Given this list of marker genes EZH1, EARS2, KAT6B, TCP11L2, IL16, ABHD14B, EBAG9, MPHOSPH6, ZFP1, CHCHD2, RNF138, RPL13, KCNJ8, SLC25A36, POLR3E, NDFIP1, CCR7 (NCBI Gene Id 1236), PER1, XCL1, BAG5, SMNDC1, RUNDC3B, SIDT1, HIGD1A, MDC1, PFN2, KLF2, SYN3, CREBL2, AMD1, MESD, DMRTA1 (NCBI Gene Id 64125), TSC22D3, RPTOR, HSH2D, DGUOK, NOP10, SMYD3, TCEAL1, SLC4A1AP, PTGES3, CD7, PLEKHA1, MBLAC2, TCF7, PARP8, KBTBD11, R3HCC1, VPS28, SYS1 (NCBI Gene Id 90196), P2RY10, HEXIM1, GNL1, PIK3IP1, IRF7, GNG5, BAMBI, CXCR6 (NCBI Gene Id 10663), ENPEP, BTG2, POLR1H, HERPUD2, DZIP1, ADAMTS15, CLCF1, ZNF394, TMEM33, DPH5, POLR2E (NCBI Gene Id 5434), GPR183, NDUFS7, MAFF, PIP4P2, ARHGEF28, NSG2, CBR1, KIAA1328, TMEM9B, PDCD2L, CD72, TRIM13 (NCBI Gene Id 93520), WDR74, POLR1C (NCBI Gene Id 9533), STXBP4, CD55, ICAM2, ECI1 (NCBI Gene Id 1632), FAM50A, FASTKD3, CLEC4G, IL7R (interleukin 7 receptor), RPL30, HSD17B8, VKORC1, RPS19, IMP3, SLC16A5, APTX, PVR, FOXP1, NOBOX, ITM2A, S1PR1, TOB2, COQ10B, KCNK1, AATF, CDC42EP3, QTRT1, FAM120B, BOLA2, TNFRSF11B, KLRK1, NOP14, ZNRF1, ZNHIT6, FYTTD1, NFU1, SETD3, MDN1, KLK8, SNX30, CUX1, UTP25, RNF167, F2RL1, TAF4B, TANC1, GPR18 (NCBI Gene Id 2841), MAML2, ARHGAP35, NFIL3, PCCA, DHX34, TRMT112, VIPR1, SFT2D3, RPL36A, SAMD3, PRPF6, JMJD6, HINT2, EVI5L, CXCR4, CAMLG, USE1 (NCBI Gene Id 55850), ZSWIM7, FCHSD2, EVL, MICU3, GBE1, TMEM59, NR1D2, ZBTB4, EGLN2, NEURL3, DDX24, ADCK2, NDUFAF4, TOB1, here is a description of the gene set: The development, homeostasis and function of B lymphocytes involve multiple rounds of B cell receptor (BCR)-controlled proliferation and prolonged maintenance. We analyzed the role of transcription factor Zfx, a recently identified regulator of stem cell maintenance, in B cell development and homeostasis. Conditional Zfx deletion in the bone marrow blocked B cell development at the pre-BCR selection checkpoint. Zfx deficiency in peripheral B cells caused impaired generation of the B-1 cell lineage, accelerated B cell turnover, depletion of mature recirculating cells, and delayed T-dependent antibody responses. Zfx-deficient B cells showed normal proximal BCR signaling, but impaired BCR-induced proliferation and survival. This was accompanied by aberrantly enhanced and prolonged integrated stress response, and delayed induction of Cyclin D2 and Bcl-xL proteins. Thus, Zfx restrains the stress response and couples antigen receptor signaling to B cell expansion and maintenance during development and peripheral homeostasis. studied in species Homo sapiens Genes down-regulated in B lymphocytes stimulated by anti-IgM for 2h: wildtype versus ZFX knockout. from publication Arenzana TL, Smith-Raska MR, Reizis B (PMID 19329779) Human Gene Set: GSE13547_WT_VS_ZFX_KO_BCELL_ANTI_IGM_STIM_2H_DN